The following is a description of a gene set: Reactome Pathway: Activation of NOXA and translocation to mitochondria NOXA is transactivated in a p53-dependent manner and by E2F1. Activated NOXA is translocated to mitochondria. species: Homo sapiens part of: Activation of BH3-only proteins, and this is the list of marker genes: E2F1, TFDP2, TP53, TFDP1 (NCBI Gene Id 7027), PMAIP1